Given this list of marker genes MMP9, KCNRG, CALM3, FMR1, GRP, GNB5, CBARP, CALM2, KCNE1, GPR35, KCNQ1, KCNE3, CALM1, CRHR1, UBQLN1, KCNE2, SUMO1, KCNAB1, CACNA1F, ANK3, here is a description of the gene set: Human Gene Set: GOBP_NEGATIVE_REGULATION_OF_CATION_CHANNEL_ACTIVITY species: Homo sapiens Any process that stops, prevents or reduces the frequency, rate or extent of cation channel activity.